The following is a description of a gene set: studied in species Homo sapiens Any process that modulates the frequency, rate, or extent of an inflammatory response to an antigenic stimulus. Human Gene Set: GOBP_REGULATION_OF_INFLAMMATORY_RESPONSE_TO_ANTIGENIC_STIMULUS, and this is the list of marker genes: FUT7, GPX1, YES1 (YES proto-oncogene 1, Src family tyrosine kinase), LTA, C3, PSMA1, GNAS, ZP3, PSMB4, CCR7, CD28, IL20RB, KARS1, PLA2G2D, FGR (FGR proto-oncogene, Src family tyrosine kinase), CD81, IL12B, IL10, MIR302E, MIR105-1, MIR19B1, PLK2, GPR17 (NCBI Gene Id 91962), MIR19A, SPN, PLCG1, TREM2, HLA-DRB1, HCK (NCBI Gene Id 3055), FCGR1A, SRC, MIR6869, SYK, FYN, NPY5R, BTK, RHBDF2, FURIN, PARK7, NPY, MAPK14, TNF, HLA-E, LYN, SELENOS, FCER1G, NLRP6, FCGR2B, MKRN2